The following is a description of a gene set: Mouse Gene Set: GOBP_PHOSPHATIDYLINOSITOL_3_PHOSPHATE_BIOSYNTHETIC_PROCESS studied in species Mus musculus The chemical reactions and pathways resulting in the formation of phosphatidylinositol-3-phosphate, a phosphatidylinositol monophosphate carrying the phosphate group at the 3-position., and this is the list of marker genes: Becn1, Atm, Pik3c3, Inpp4a, Pik3c2a, Inpp5e (NCBI Gene Id 64436), Pik3cg, Pik3r4, Pik3cb, Pik3cd, Ptprq, Fig4, Uvrag, Inpp4b, Pik3c2g, Atg14, Pik3ca, Pik3r1, Pik3c2b